The following is a description of a gene set: species: Homo sapiens Genes up-regulated in lymph nodes from patients with mantle cell lymphoma (MCL) compared to the non-malignant hyperplastic lymph nodes. from publication Hofmann WK, de Vos S, Tsukasaki K, Wachsman W, Pinkus GS, Said JW, Koeffler HP (PMID 11468180) An imbalance between cellular apoptosis and survival may be critical for the pathogenesis of lymphoma. Therefore, the gene expression pattern in lymph node preparations from patients with mantle cell lymphoma (MCL) was compared to the pattern in nonmalignant hyperplastic lymph nodes (HLs). Oligonucleotide microarray analysis was performed comparing 5 MCLs to 4 HLs using high-density microarrays. The expression data were analyzed using Genespring software. For confirmation, the expression of selected genes was analyzed by real-time polymerase chain reaction using the RNA extracted from 16 MCL and 12 HL samples. The focus was on genes that were at least 3-fold down-regulated in MCL; in addition to the B-cell leukemia 2 (BCL2) system other apoptotic pathways were altered in MCL. The FAS-associated via death domain (FADD) gene that acts downstream of the FAS cascade as a key gene to induce apoptosis was more than 10-fold down-regulated in MCL. Furthermore, the death-associated protein 6 (DAXX) gene, the caspase 2 (CASP2) gene, and the RIPK1 domain containing adapter with death domain (RAIDD) gene, which are key genes in other proapoptotic pathways, were also decreased in the MCL samples. The suggestion is made that in addition to the known overexpression of cyclin D1, which drives entry into the cell cycle, disturbances of pathways associated with apoptosis contribute to the development of MCL. (Blood. 2001;98:787-794) Human Gene Set: HOFMANN_CELL_LYMPHOMA_UP, and this is the list of marker genes: IL18, TAF5, TRIM22, NCK1, ATF1 (activating transcription factor 1), REL, H1-0, TFDP2, ILF3, CXCL8, SKP2, TFAP2A, CCNG2, RXRG, IL3, PRKCB, FLI1, RBBP5, KDM5A, MYC, YES1, GPR68, NRAS, MYBL2, RB1, MLLT10, COPS5, E2F5, IL13RA1, PBX2, IFNA4, RAB2A, DTYMK, CEBPG, IRF8, MDM2, IL1R1, CCND1, IL13, MAPK8, RAB9A, CDK4, TAF13, BNIP2, BLK, LIFR, TBP, CKS1B